The following is a description of a gene set: species: Mus musculus The attachment of one cell to another cell via a cadherin, transmembrane proteins having repeating extracellular calcium ion binding domains. Mouse Gene Set: GOBP_CELL_CELL_ADHESION_MEDIATED_BY_CADHERIN, and this is the list of marker genes: Mmp24, Cdh2, Cdh3, Adam19, Wnt5a, Mad2l2, Cdh4, Cdh24, Cd2ap, Cdh5, Cdh7, Wnt3a, Ctnnb1, Plekha7, Cdh20, Tjp1, Notch1, Epcam, Ppm1f, Vegfa, Cdh13, Rgcc, Bhlha15, Cdh17, Cdhr18, Ptpru, Cdh19, Smad7, Cdh6, Cdh9, Cdh1, Afdn, Flot1, Bmp6, Ctnnd1, Tgfb1, Cdh12, Cdh15, Fer, Nexmif, Cdh26, Cdh11, Cdh10, Cdhr2, Dennd6a, Cdh8, Notch4, Cdh18, Cdh22